The following is a description of a gene set: Human Gene Set: WP_RIBOFLAVIN_AND_COQ_DISORDERS studied in species Homo sapiens Riboflavin and CoQ disorders, and this is the list of marker genes: COQ9, ETFA, SLC52A2, COQ2, RFK, PDSS1 (NCBI Gene Id 23590), SLC52A1, COQ7, PDSS2, COQ8A, COQ6, APTX, FLAD1, ETFDH